The following is a description of a gene set: Human Gene Set: GOBP_ENGULFMENT_OF_APOPTOTIC_CELL species: Homo sapiens The removal of the apoptotic cell by phagocytosis, by a neighboring cell or by a phagocyte., and this is the list of marker genes: XKR6, BECN1 (beclin 1), THBS1, RAC1, XKR4, MEGF10, XKR7, XKR8, ADGRB1, ABCA7, ALOX15, TREM2